The following is a description of a gene set: from publication Hoek KL, Samir P, Howard LM, Niu X, Prasad N, Galassie A, Liu Q, Allos TM, Floyd KA, Guo Y, Shyr Y, Levy SE, Joyce S, Edwards KM, Link AJ (PMID 25706537) Systems biology is an approach to comprehensively study complex interactions within a biological system. Most published systems vaccinology studies have utilized whole blood or peripheral blood mononuclear cells (PBMC) to monitor the immune response after vaccination. Because human blood is comprised of multiple hematopoietic cell types, the potential for masking responses of under-represented cell populations is increased when analyzing whole blood or PBMC. To investigate the contribution of individual cell types to the immune response after vaccination, we established a rapid and efficient method to purify human T and B cells, natural killer (NK) cells, myeloid dendritic cells (mDC), monocytes, and neutrophils from fresh venous blood. Purified cells were fractionated and processed in a single day. RNA-Seq and quantitative shotgun proteomics were performed to determine expression profiles for each cell type prior to and after inactivated seasonal influenza vaccination. Our results show that transcriptomic and proteomic profiles generated from purified immune cells differ significantly from PBMC. Differential expression analysis for each immune cell type also shows unique transcriptomic and proteomic expression profiles as well as changing biological networks at early time points after vaccination. This cell type-specific information provides a more comprehensive approach to monitor vaccine responses. Genes down-regulated in myeloid dendritic cell 3d vs 0d in adults after exposure to 2011-2012 trivalent inactivated vaccine (A/California/7/09 (H1N1), A/Perth /16/2009 (H3N2), B/Brisbane/60/2008), time point 3D. Comment: Down-regulated DE RNA transcripts (down >= 1.5x) shared between both TIV-vaccinated donors Human Gene Set: HOEK_MYELOID_DENDRITIC_CELL_2011_2012_TIV_ADULT_3DY_DN studied in species Homo sapiens, and this is the list of marker genes: CCDC106, DLGAP4-AS1, TMEM120B, PKMYT1, CARS1-AS1 (NCBI Gene Id 100852407), MIR3648-1 (NCBI Gene Id 100500862), NME8, IDI2, LINC00920, SLC7A5, TAB3-AS2, GAS8, DPEP3, RO60, RNU6-1, SNORD5, SNORA73A, RXFP4, RN7SK, MSMP, TMOD4, LINC02631, CC2D2B, B3GNT9, GATC, ZMYM4-AS1, SNORA8, EGR1, MAFF, CCNE2, SNORA40, DLG2, TAB3-AS1